The following is a description of a gene set: Any process that activates or increases the frequency, rate or extent of the regulated release of dopamine. Mouse Gene Set: GOBP_POSITIVE_REGULATION_OF_DOPAMINE_SECRETION species: Mus musculus, and this is the list of marker genes: Oprk1, Pcp4, Syt1, Slc18a1, Npy2r, Rtn4, Pink1, Cxcl12, Chrnb2, Htr6